The following is a description of a gene set: Human Gene Set: GOBP_GOLGI_TO_PLASMA_MEMBRANE_PROTEIN_TRANSPORT The directed movement of proteins from the Golgi to the plasma membrane in transport vesicles that move from the trans-Golgi network to the plasma membrane. studied in species Homo sapiens, and this is the list of marker genes: RAB26, RACK1, VAMP3, VAMP5, ANXA13, PKDCC (protein kinase domain containing, cytoplasmic), NSF, GGA2, ATP2C1, KIF13A, VAMP4, GCC2, CLN3, GOLPH3L, RAB31, BBS2, ARFRP1, RSC1A1, SPTBN1, RAB11FIP3, PREPL, KRT18, BBS1, PHAF1, VAMP2, LYPLA1, SYS1, RAB10, ANK3, BLZF1, CSK, GOLGA4, CNST, OPTN, AMN, RAB11A, MACF1, ACSL3, LYPLAL1, GGA3, GGA1, GOLPH3, GOLGA7, RAB34